Given this list of marker genes CUL1, NFKB2, MAPKAPK3, HMGB1, MAP3K8, DUSP3, MAPK7, TNIP2, ECSIT, TICAM1, TAB3, UBE2V1, MAP2K7, UBB, SAA1, JUN, S100A12, PELI2, TLR7, DUSP6, TAB1, DUSP4, PPP2CA, MAPK8, IRAK1, MAPKAPK2, CREB1, N, MAP2K3, NOD2, TIFA, NKIRAS2, BTRC, APP, RPS6KA5, IRAK2, MAP2K6, SKP1, MAP2K1, N4BP1, TLR9, ALPK1, IKBKG, ATF1, MAPK1, IKBKB, NFKBIB, LRRC14, RPS6KA1, UBC, FBXW11, PPP2R1B, DUSP7, NFKBIA, TICAM2, NKIRAS1, MYD88, USP18, MAPK9, MEF2C, RIPK2, CASP8, IKBIP, S100B, UBA52, MAP2K4, UBE2N, IRAK4, VRK3, ELK1, RPS6KA3, AGER, MAPK10, PPP2R1A, FOS, PELI1 (NCBI Gene Id 57334), RELA, CHUK, LY96, MEF2A, ATF2, TLR4, PELI3, CD14, USP14 (NCBI Gene Id 9097), NLRC5, NLRX1, TAB2, MAPK14, NFKB1, RPS27A, TRAF6, MAP3K1, MAP3K7, MAPK11, NOD1, RPS6KA2, PPP2CB, TP53, PPP2R5D, MAPK3, TRAF2, here is a description of the gene set: TRAF6 mediates NFkB activation via canonical phosphorylation of IKK complex by TAK1. TRAF6 and TAK1 also regulate MAPK cascades leading to the activation of AP-1. Reactome Pathway: TRAF6 mediated induction of NFkB and MAP kinases upon TLR7/8 or 9 activation studied in species Homo sapiens part of: MyD88 dependent cascade initiated on endosome